The following is a description of a gene set: from publication Yevshin I, Sharipov R, Kolmykov S, Kondrakhin Y, Kolpakov F (PMID 30445619) Genes containing one or more binding sites for (LHX4) in their promoter regions (TSS -1000,+100 bp) as identified by GTRD version 20.06 ChIP-seq harmonization. Human Gene Set: LHX4_TARGET_GENES studied in species Homo sapiens, and this is the list of marker genes: RAB7B, ANXA2, SEMA4D, LINC02564, TSC22D4, GALNT6, ARIH1, RNA5SP400